The following is a description of a gene set: Human Gene Set: GOBP_HEART_FORMATION The developmental process pertaining to the initial formation of the heart from unspecified parts. This process begins with the specific processes that contribute to the appearance of the heart field and the arrival of cardiac neural crest to the heart region. The process ends when the structural rudiment is recognizable. studied in species Homo sapiens, and this is the list of marker genes: LEMD2, BMP4, LRP2, SOX17, NOTCH1, EXT1, PIM1, WNT11, POU5F1, ROBO2, BMPR1A, WNT5A, ISL1, FOXH1, AXIN2, SMARCD3, RBPJ, ROBO1, MKS1, HAND2, EYA1, GATA5, MIR20A, MEF2C, TBX5, MESP1, SIX1, RBM20, EMP2, CTNNB1, DKK1, FOLR1, BMP2, HES1